The following is a description of a gene set: species: Mus musculus Mouse Gene Set: chrYA1, and this is the list of marker genes: Gm20821, 1700020D14Rik, Gm20788, Gm20807, Gm20828, Gm20918, Gm28919 (predicted gene 28919), Gm21379, Gm32033, Gm25565, Gm21301, Gm33112, Gm29354, Gm28916, Gm34550, Gm20915, Gm36467, Ssty1, Rhoay-ps3, Gm29330, H2al2b (NCBI Gene Id 620181), Gm21854, Gm34716, Gm21310, Gm20772, Gm2098, Gm8498, 4921509O09Rik, Gm8521, Gm20831, Gm28098, Gm21064, Gm8446, n-R5s1, Gm21678, Vmn2r-ps139, Gm4017, Gm18665, Srsy, Gm8510, Gm20815, Rbmyf3, Sry, Gm36398, Gm28357, Gm35843, Gm21828, Gm20928, Tspy-ps, Gm31511, Gm29475, Gm20836, Gm36728, Rbmyf6, Gm31942, Uba1y, Gm20826, Rhoay-ps2, Gm30174, Gm20851, Ddx3y, Gm21147, Gm29048, Gm20775, Rbmyf1, Gm2325, Gm29349 (predicted gene 29349), Rhoay-ps1, Gm21454, Uty, Gm30638, Gm8480 (NCBI Gene Id 667143), Gm8506, Kdm5d, Vmn2r-ps149, Gm28442, Gm30686, Gm28397, Gm20833, Gm20824, Gm21292, Gm20825, Gm21719, Gm33191, Gm21156, Gm31186, Gm30312, Gm32295, Gm21139, Gm36261, Gm21763, Usp9y, Gm29525, Gm20777, H2al2c, Uba1y-ps2, Zfy2, Gm35134, Gm20877, Gm20770, Gm20781, Gm21778, Gm29142, Gm28656, Gm21440, Rbmyf8, Gm8525, Gm20834, Gm17790, Gm21809, Rbmyf7, Gm35108, Zfy1, Gm30353, Gm28657, Gm6137, Gm20822, Rbmyf5 (RNA binding motif protein Y-linked family member 5), Gm30737, Gm20776, Uba1y-ps1, Gm28998, Gm28576, Rbmy, Gm28171, Gm2316, Gm18798, Gm29043, Gm29089, Gm20812, Gm28574, Gm20830, Gm18797, Gm18796, Gm8502, Gm21660, Gm34015, Gm28951, Eif2s3y, Gm31260, Gm32447, Gm21812, Rbm31y, Gm21425, Gm20914, Gm20773, Gm29554 (NCBI Gene Id 102638793), Rbmyf2, Gm28649, Rbmyf9, Gm18177, Gm35070, Gm20873, Gm28510, Gm21244, Gm20737, Gm38185 (NCBI Gene Id 108168636)